Given this list of marker genes APC, here is a description of the gene set: Reactome Pathway: APC truncation mutants are not K63 polyubiquitinated part of: Signaling by APC mutants studied in species Homo sapiens APC has been shown to be reversibly modified with K63-linked polyubiquitin chains. This modification is required for the assembly of the destruction complex and subsequent degradation of beta-catenin in the absence of WNT ligand. K63-polyubiquitination of APC is lacking in a number of colorectal cancer cell lines expressing truncated forms of APC, and these lines have aberrantly high beta-catenin levels and WNT pathway activation.